Given this list of marker genes Ift43, Wdr19, Dynll1, Wdr35, Dync2i2, Dynlt2b, Dync2h1, BC048507 (NCBI Gene Id 408058), Bbs1, Cilk1, Dync2i1, Ift122, Ift140 (intraflagellar transport 140), Dync2li1 (dynein cytoplasmic 2 light intermediate chain 1), Ttc21b, Ttc21a, here is a description of the gene set: The directed movement of large protein complexes along microtubules from the tip of a cilium (also called flagellum) toward the cell body, mediated by motor proteins. Mouse Gene Set: GOBP_INTRACILIARY_RETROGRADE_TRANSPORT studied in species Mus musculus